Given this list of marker genes Lypla1, Pkdcc, Wnk4, Sfn, Ppp2r5a, Tmed2, Tgfb1, Sapcd2, Cltc (clathrin heavy chain), Lyplal1, Cdh1, Rhoq, Wnk3, Mrap2, Lztfl1, Lrrc15, Dab2, Lypd1, Ap2m1, Abi3, Pid1, Tmbim1, Bcl2l1, Hectd1, Wnk1, Csk, Tmem59, Ngdn, Picalm (phosphatidylinositol binding clathrin assembly protein), Mrap, Ppfia1, Numb, here is a description of the gene set: Any process that stops, prevents or reduces the frequency, rate or extent of protein localization to cell periphery. Mouse Gene Set: GOBP_NEGATIVE_REGULATION_OF_PROTEIN_LOCALIZATION_TO_CELL_PERIPHERY studied in species Mus musculus